The following is a description of a gene set: Mouse Gene Set: MIR_6964_3P from publication Chen Y, Wang X (PMID 31504780) Genes predicted to be targets of miRBase v22 microRNA mmu_miR_6964_3p in miRDB v6.0 with MirTarget v4 prediction scores > 80 (high confidence targets). species: Mus musculus, and this is the list of marker genes: Syt9, Zfp654, Setx, Bcl2, Spp1 (secreted phosphoprotein 1), Ankrd49, D430041D05Rik, Lmbrd1, Cacna1a, Cpeb3, Tbc1d12, Zfp449, M6pr, Orc4, Spty2d1, Tmem45a2, Zfp473, Ash1l, Prkcq, Zyg11b, Ddx46, Grb2, Ctag2l2, Map3k2, Zfp799, Nampt, Mob1a, Kank1, Smap2, Spin1, Wapl, Tcerg1, Nlk, Glipr1l2, Rapgef4, Med14, Atp6v1g3, Prlr, Gmnc, Magi3, Fgd1, Arpc1b, Med19, Fut9, Eya4, Gpm6a, Akap17b, Rc3h1, Plcl2 (NCBI Gene Id 29868), Tenm3, Cep55 (centrosomal protein 55), Ngb, Mtm1, Commd8, Dnajb9, Tent2, Ccdc71l, Fgfrl1, Msl2, Mmut, Cobll1, Foxd1, Arid1b, Plce1, Zfp953, Gm3604, Mef2a, Pde3b, Zfp24, Plp1, Grid1, Gucy2c, Cnot6l, D16Ertd472e, Gja6 (NCBI Gene Id 414089), Tasor2 (NCBI Gene Id 105203), Plekhh1, Zfp81, Usp34, Pccb, Bicd1, Cycs, Usp14, Dmtf1l, Bcl11b, Fam204a (family with sequence similarity 204, member A), Zfp945, Lpp, Rnpc3, Sema3e, Zfp558, E030030I06Rik, Cdk6, Cd300ld, Pacc1, Rassf6, Dmxl1, Tex26, Fdx1 (ferredoxin 1), Tmem116, D830030K20Rik, Cflar, Nipbl, Mllt3, Myo19, Vegfa, Syncrip (NCBI Gene Id 78260), Pgrmc2, Dmd, Lipa, Ccdc83, Pfn2 (NCBI Gene Id 18645), Bltp3b, Skil, Zfp871, Pdzd7, Igsf10, Sox21, Srp9, Uty, Bclaf1, Iqub, Nid2, Slc22a6, Cisd2, Bicdl2, Cluap1, Cebpzos (NCBI Gene Id 68554), Dock3, Sntg1, Xrcc5, Tsc22d2, Grpr, Vip, Cyria, Kctd8, Prokr2, Foxc2, Exo1, Negr1, Scg2, Fer, Rgs20, Emc7, Dcaf1, Cpt1a, Glis1, Tigd4, Syt11, Pgbd5, Prkar2b, Ppp3r1, Mmp21, Gprc5b, Ndrg1, Oprk1, Fzd8, Rnf32